The following is a description of a gene set: The gene expression program underlying the specification of human cell types is of fundamental interest. The study authors generated human cell atlases of gene expression and chromatin accessibility in fetal tissues. For gene expression, the study authors applied three-level combinatorial indexing to >110 samples representing 15 organs, ultimately profiling ~4 million single cells. The study authors leveraged the literature and other atlases to identify and annotate hundreds of cell types and subtypes, both within and across tissues. Our analyses focused on organ-specific specializations of broadly distributed cell types (such as blood, endothelial, and epithelial), sites of fetal erythropoiesis (which notably included the adrenal gland), and integration with mouse developmental atlases (such as conserved specification of blood cells). These data represent a rich resource for the exploration of in vivo human gene expression in diverse tissues and cell types. Marker genes curated from the annotated cluster as represented in the Descartes Human Gene Expression During Development database. studied in species Homo sapiens Human Gene Set: DESCARTES_FETAL_KIDNEY_ERYTHROBLASTS from publication Cao J, O'Day DR, Pliner HA, Kingsley PD, Deng M, Daza RM, Zager MA, Aldinger KA, Blecher-Gonen R, Zhang F, Spielmann M, Palis J, Doherty D, Steemers FJ, Glass IA, Trapnell C, Shendure J (PMID 33184181), and this is the list of marker genes: ABCB10, H2AC16, CDC20P1, FHDC1, MICAL2, SLC30A10, SLC22A4, C17orf99, SNCA, UBAC1, PIGQ, YPEL4, SLC25A37, SLC2A1-DT, EPOR (erythropoietin receptor), ANKRD9, ARRDC2, C9orf85P2, SEC14L4, GYPB, SELENBP1, TFR2, TBC1D22B, TBCEL, NCEH1, HBZ, ANK1, HMGN1P8, BPGM, ABCB6, RSAD2, FKBP8, HBB (NCBI Gene Id 3043), RNF123, RHCE, TRIM58, SNORA79, MAP2K3, CPB1, TDH, FLACC1, SMIM1, TF, PRDX2, CCNE1, ALAD, CTSE, HBQ1, HBA2, HBA1, UGT1A10, BSG, HAGH, DPF3, ARG1, ESPN, SPMAP2L, EPB42, PHOSPHO1, PPME1, SLC6A8, PPOX, AURKA, CD46P1, TLCD4, HMBS, SLC2A1, TLCD4-RWDD3, SLC4A1, HBG1, DCAF12, HBG2, SNX22, TSPAN5 (tetraspanin 5), RN7SL574P, ANKLE1, ICAM4, NARF, HBE1, LINC02506, PIP5K1B, UROS, MYT1, SPTB, MYL4, TERC, UBE2O, SMIM5, CPOX, FAM83D, CA8, GLRX5 (glutaredoxin 5), ATG14, SLC14A1, SOX6, TMEM63B, BLVRB (NCBI Gene Id 645), HBM, SLC36A1, FAM229A, FBXO9, ABCC13, FAM201A, MARCHF8, KLC3, ABCB5, HARBI1, QSOX2, ACHE, GYPA, RHD, CROCCP2, SBF2-AS1, DHRS13, SNORD13E, TRIM10, CAT, AEN, TMEM81, TMCC2, NRIR, KLF1, TMOD1, CYP4A22-AS1, RELN, ERICH2-DT, RUNDC3A-AS1, MARCHF3, GFI1B, RUNDC3A, RNF224, OSBP2 (NCBI Gene Id 23762), ART4, ENSG00000260592, RGS6 (NCBI Gene Id 9628), RFESD, ERMAP, ALAS2, LINC01399, ARL4A, TENT5C, TSPO2, DYRK3, SPTA1, SLC25A39, TCP11L2, EIF5AP2, SLC5A4-AS1, HEMGN, TANGO2, ACSL6, UBR2, YOD1, CR1L, AMMECR1 (AMMECR nuclear protein 1), NFE2, TSPAN5-DT, GYPE, FECH, SLC43A1 (solute carrier family 43 member 1), TRAK2, GALNT5, AHSP, XPO7, KRT1, GCLC, KLK1, TESC, SLC6A9 (NCBI Gene Id 6536)